Given this list of marker genes Nr1h2, Ptch1, Shh, Zdhhc8 (NCBI Gene Id 64503), Pon1, Abca13, Apoc3, Pltp, Lamtor1, Sec24a, Lrp1, Gps2, Lipg, Pcsk9, Ces1b, Nr1h3, Abca5, Anxa2, Abcg4, Ces1g, Yjefn3, Abca7, Naxe, Trem2, Ces1h, Furin, Ttc39b, Abcb4, Ces1e, Abca2, Apoa1, Ces1d, Irak1, Adipoq, Apoa4, Ces1f, Ces1a, Abca12, Srebf2, Washc1, Apoa2, Apoe, Ces1c, Sirt1, Apoc1, Abca8b, Nfkb1, Eepd1, Apoc2l, Commd1, Cav1, Osbpl6, Apoc2, Abca8a, Abca1, Ldlrap1, Abcg1, Nus1, Egf, Arv1, Scp2, Abca3, Nfkbia, Ttc39d, Pparg, Tmem97, Pla2g10, here is a description of the gene set: species: Mus musculus Mouse Gene Set: GOBP_REGULATION_OF_STEROL_TRANSPORT Any process that modulates the frequency, rate or extent of the directed movement of sterols into, out of or within a cell, or between cells, by means of some agent such as a transporter or pore.